Given this list of marker genes Lsm6, Snrpb, Ppihl, Snrpd3, Snrnp200, Eftud2, Lsm2, Snrpn, Snrpg, Ppih, Snrpert, Lsm8, Snrnp40, Snrpe, Usp39, Txnl4b, Snrpa, Snrpf, Prpf31, Snrnp27, Prpf8, Prpf4, Lsm4, Snrpd2, Ddx23, Prpf6, Lsm3, Prpf3, Snrpd1, Txnl4a, Zmat2, Prpf18, Rbm42, Lsm5, Lsm7, Sart1, Snu13, here is a description of the gene set: A spliceosomal snRNP complex that is formed by the association of the U4/U6 (or U4atac/U6atac) snRNP with the U5 snRNP. Mouse Gene Set: GOCC_SPLICEOSOMAL_TRI_SNRNP_COMPLEX species: Mus musculus